The following is a description of a gene set: species: Homo sapiens Human Gene Set: GOBP_POSITIVE_REGULATION_OF_LYSOSOMAL_PROTEIN_CATABOLIC_PROCESS Any process that activates or increases the frequency, rate or extent of lysosomal protein catabolic process., and this is the list of marker genes: LRP2, GGA3, LRP1, MARCHF2, LDLR